The following is a description of a gene set: studied in species Mus musculus Mouse Gene Set: GOMF_CALCIUM_AND_CALMODULIN_RESPONSIVE_ADENYLATE_CYCLASE_ACTIVITY Catalysis of the reaction: ATP = 3',5'-cyclic AMP + diphosphate, stimulated by calcium-bound calmodulin., and this is the list of marker genes: Adcy1, Adcy6, Adcy8, Adcy5, Adcy3